Given this list of marker genes COX7A2, COX7B, CD46, SNRNP200, ACTN2, ERCC5, STIP1, GLUL, EIF2S2, ADA, LPGAT1, GSTM3, ATF4, COPB1, PTPRN, RPN1, ATP6V1D, GCHFR, CRNKL1, NRF1, COX6A1, CYC1, RBBP5, CYCS, here is a description of the gene set: from publication Baris O, Mirebeau-Prunier D, Savagner F, Rodien P, Ballester B, Loriod B, Granjeaud S, Guyetant S, Franc B, Houlgatte R, Reynier P, Malthiery Y (PMID 15806164) Human Gene Set: BARIS_THYROID_CANCER_UP The oncogenic pathways in mitochondrial-rich thyroid carcinomas are not clearly understood. To investigate the possible implication of mitochondrial abundance in the genesis of thyroid tumors, we have explored the gene expression profile of six oncocytic carcinomas and six mitochondrial-rich papillary carcinomas using cDNA-microarray technology. A supervised approach allowed us to identify genes differentially expressed in the two types of carcinoma. These genes were classified according to their ontologic profiles. Three genes, NOS3, alpha-actinin-2 and alpha-catenin, suspected of playing a role in tumor genesis, were explored by quantitative RT-PCR analysis and immunohistochemistry. Of the genes overexpressed in papillary carcinomas, 51% were involved in cell communication. Of the genes overexpressed in oncocytic carcinomas, 84% were involved in mitochondrial and cellular metabolism. Our results suggest that mitochondrial respiratory chain complexes III and IV play a significant role in the regulation of reactive oxygen species production by oncocytic tumors. species: Homo sapiens Genes up-regulated in oncocytic follicular carcinoma (FTC) vs mitochondrial-rich papillary carcinoma (PTC) types of thyroid cancer.